Given this list of marker genes CPNE8, NQO1, MIR29B2, MSMO1, IAH1, ADRB2, CYP51A1, ANKRD33B, KCTD21, MIR221, INSIG1 (insulin induced gene 1), SQLE, PTGR1, SLC2A3, SQSTM1, LPIN2, here is a description of the gene set: from publication Gargalovic PS, Imura M, Zhang B, Gharavi NM, Clark MJ, Pagnon J, Yang WP, He A, Truong A, Patel S, Nelson SF, Horvath S, Berliner JA, Kirchgessner TG, Lusis AJ (PMID 16912112) Human Gene Set: GARGALOVIC_RESPONSE_TO_OXIDIZED_PHOSPHOLIPIDS_BROWN_UP Oxidized phospholipids are thought to promote atherogenesis by stimulating endothelial cells (ECs) to produce inflammatory cytokines, such as IL-8. In studies with mouse models, we previously demonstrated that genetic variation in inflammatory responses of endothelial cells to oxidized lipids contributes importantly to atherosclerosis susceptibility. We now show that similar variations occur in cultured aortic ECs derived from multiple heart transplant donors. These variations were stably maintained between passages and, thus, reflect either genetic or epigenetic regulatory differences. Expression array analysis of aortic EC cultures derived from 12 individuals revealed that >genes were regulated by oxidized phospholipids. We have used the observed variations in the sampled population to construct a gene coexpression network comprised of 15 modules of highly connected genes. We show that several identified modules are significantly enriched in genes for known pathways and confirm a module enriched for unfolded protein response (UPR) genes using siRNA and the UPR inducer tunicamycin. On the basis of the constructed network, we predicted that a gene of unknown function (MGC4504) present in the UPR module is a target for UPR transcriptional activator ATF4. Our data also indicate that IL-8 is present in the UPR module and is regulated, in part, by the UPR. We validate these by using siRNA. In conclusion, we show that interindividual variability can be used to group genes into pathways and predict gene-gene regulatory relationships, thus identifying targets potentially involved in susceptibility to common diseases such as atherosclerosis. Genes from the brown module which are up-regulated in HAEC cells (primary aortic endothelium) after exposure to the oxidized 1-palmitoyl-2-arachidonyl-sn-3-glycerophosphorylcholine (oxPAPC). species: Homo sapiens